The following is a description of a gene set: Mouse Gene Set: GOBP_NEGATIVE_REGULATION_OF_LYMPHOCYTE_MIGRATION studied in species Mus musculus Any process that stops, prevents or reduces the frequency, rate or extent of lymphocyte migration., and this is the list of marker genes: Klrk1, Cd200r1, Adtrp, Cd200, Lrch1, Apod, Akt1, Il27ra, Mia3, Padi2, Gcsam, Ripor2, Ccl12, Cd69, Wasl